The following is a description of a gene set: Any process that modulates the frequency, rate or extent of lymphangiogenesis. Human Gene Set: GOBP_REGULATION_OF_LYMPHANGIOGENESIS species: Homo sapiens, and this is the list of marker genes: VEGFC, VEGFA, FOXC1, MIR9-1 (microRNA 9-1), EPHA2, CCBE1, VASH1